Given this list of marker genes ARRDC1, MED18, MFSD10, C1QL3 (NCBI Gene Id 408250), PLXNA3, CPLANE2, TRIM28 (NCBI Gene Id 96054), CA11 (carbonic anhydrase 11), GBX1, CCDC83, GABRG3, CBLC, ABCB8, SSR2, RGS7, ARHGEF9, H3C4, CDCP1, DBH, WHRN, GABRR2, TMA16, KRT81, DSP, OARD1, PNPLA3, ORC1, DRP2, SYT11, MTA2, RBBP4, FREM2, PTH2R, NPEPPS, ACOT8, OTOG, MINK1, C12orf56, CFI, CACNG4, PHGDH, LDLRAD3, ANKZF1, PLA2G10, RPL18, PAX1, ZIK1, HMGCS1, TRMO, ELAVL4, SORCS2, SLC44A2, TMEM151A, PPP6R1, CCDC157, CYP2C19, ATP1A3, TP63, GSTM2, SLC2A5, BZW2, PRR23A, GATC, OGFOD2, FGFR3, CKAP2L, SF1, RGS12, PLS3, TMEM71, TNFRSF4, CRYGB, AKT1, P2RX2, TRANK1, KDSR, CYBRD1, PKP1 (NCBI Gene Id 5317), PTGDR, MICALL1, UBE3D, RPS14, POU2F1, ABCA2, TBX20, DPPA2, SLC17A3, NFE2L1, NFATC1, RASL10B, MMP9, LRATD1, MAP3K14, TSPY1, ELMO1, CACNA1B, XPO7, PNMT, NEAT1, NMUR2, TTC39B, SIX5, ARHGAP26, TECR, NDUFB11, CYP4A22, TMEM123, RPS15A, IGFBP4, ZIM3, AJUBA, SPACA4, ZNF563, NETO1, MTM1, GDF11, SOWAHB, LCE1A, CARF, GTPBP2, SV2B, DDX3X, SAMD4B, ATRX, CCNJL, S100A14, WEE2 (WEE2 oocyte meiosis inhibiting kinase), CLMN, BICD1, PYGO2, TTC38, KCTD7, ECT2, NXPE3, DFFA, PRSS44P, TRIM29, KCNH1, NDUFB5, ST6GAL2, INF2, DDB1, ADAMTS10, NDRG2, VASP, NXPH3, DMRTC1B, SEBOX, ADAT2, FAT1, NAT8, SCGB3A1, TMC2, DSCAM, SRY, HS3ST2, JRK, NUDCD3, HNRNPH1, CHADL, ZNF398, KIF3C, GOLGA7B (NCBI Gene Id 414267), DCST2, ARF1, ANKUB1, NRIP3, GHR, ERMN, WNT7B, FSD1, EIF5A, PAPSS1, GABPB2, ANP32A, GABRB1, HCRTR2, MCEMP1, NPY, LIX1, ANAPC5, CIT, OCA2, ASXL3, NECTIN1, SMARCD2, ACTN4, PAM, CCDC122, GPR45, CYB5R2, ZC3H11A, ENTREP1, COL19A1, LRRCC1, HNRNPL, HYDIN, MARK1, GDF3, ZNF205, here is a description of the gene set: Genes down-regulated in HMC-1 (mast leukemia) cells: incubated with the peptide ALL1 versus stimulated with T cell membranes. from publication Baram D, Dekel O, Mekori YA, Sagi-Eisenberg R (PMID 20190146) species: Homo sapiens Human Gene Set: GSE19888_ADENOSINE_A3R_INH_VS_TCELL_MEMBRANES_ACT_MAST_CELL_DN We demonstrate that the G protein Gi3 is the cellular target of the adenosine A3 receptor (A3R). By using a cell permeable peptide comprising the C-terminal end of Gαi3 fused to an importation sequence (ALL1) as a selective inhibitor of Gi3 signaling, we show that by coupling to Gi3, the A3R stimulates multiple signaling pathways in human mast cells, leading to upregulation of cytokines, chemokines and growth factors.Following contact with activated T cell membranes, endogenous adenosine binds to and activates the A3R, resulting in Gi3-mediated signaling. Specifically, the majority of ERK1/2 signaling initiated by contact with activated T cell membranes, is mediated by Gi3, giving rise to ALL1-inhibitable cellular responses. These results unveil the physiological GPCR that couples to Gi3 and establish the important role played by this G-protein in inflammatory conditions that involve adenosine-activated mast cells. We used microarrays to detail the effect of ALL1 on gene expression of HMC-1 cells activated directly by the A3 receptor, or by contact with activated T cell membranes.